The following is a description of a gene set: Human Gene Set: HEBERT_MATRISOME_TNBC_BRAIN_METASTASIS_TUMOR_CELL_DERIVED studied in species Homo sapiens We have previously developed methods for enriching tissue samples for their ECM protein content by taking advantage of the relative insolubility of the ECM, and we have used these techniques in conjunction with mass spectrometry-based proteomics to profile the matrisome, the complete collection of both core ECM and ECM-associated proteins, in several different cancers. Here we define and compare the ECM components of metastatic niches and how they differ among the specific secondary sites common in TNBC. For this purpose, we use as a model the MDA-MB-231 human TNBC cell line, originally derived from a patient pleural effusion (24), which is capable of metastasizing to the brain, lungs, liver and bone marrow in mouse xenografts. We identify which ECM proteins are commonly elevated at multiple different metastatic sites, and which are preferentially elevated in particular sites. We investigate how these specific ECM proteins, as well as the tumor matrix overall, are differentially produced by the tumor and stromal cells; in this paper, we use stromal to include all cells in the tumor that are not tumor cells. These comparisons did not simply identify the most elevated proteins in each tissue, but rather the proteins most significantly different in abundance in one tissue relative to all others. Separate analyses were conducted for tumor-cell-derived (human) and stroma-derived (mouse) proteins. In this study, we performed an unbiased, quantitative mass spectrometric survey of ECM proteins present in MDA-MB-231 breast cancer xenograft metastases to the brain, lungs, liver and bone marrow. This gene set lists the tumor-cell secreted matrisome proteins found in significantly higher abundance in TNBC brain metastasis niche compared to TNBC bone, liver and lung metastatic niches. from publication Hebert JD, Myers SA, Naba A, Abbruzzese G, Lamar JM, Carr SA, Hynes RO (PMID 32019869) Tumor cell-derived matrisome proteins found in significantly higher abundance in TNBC brain metastasis niche compared to TNBC bone, liver and lung metastatic niches., and this is the list of marker genes: AGRN, FREM1, COL4A5, CSPG4, SERPINB1, CBLN1, LGALS3, INTS14, CD109, SERPINH1, HCFC1, HMCN1